The following is a description of a gene set: species: Homo sapiens Neighborhood of MT4 metallothionein IV in the MORF expression compendium Human Gene Set: MORF_MT4 Neighborhood of MT4, and this is the list of marker genes: FOXE1, MOK, AFF2, PVT1, NRTN (neurturin), CRYBA4, PAX8, CDK13 (cyclin dependent kinase 13), DTNA, MTX1, GLE1, KRT33A, PLIN3, LTK, ZNF592, BTD, DTX4 (NCBI Gene Id 23220), CTRL, ECE2, BRD1, NCKIPSD, RFC1, LAIR1, NEURL1, SFSWAP, CPSF4, LSM12, CSTF3, PEX6, B4GALT3, COLQ, SPEF1, SLC22A6, ATP6V1B1, IPCEF1, CNOT2, NR3C1, PCGF1, F7, PIK3CB, POU6F1, FUT6, PHF21A, ATP6V0A2, TMEM11, ZP2, KRT86, ZNF32, RANBP2, HTR4, CD8B, CLPX, CHD9, CNTN2, NRP2, FOXN3, ROCK1, HAUS5, UGT2B15, SUMO4, AAK1, MT4, NR2C1 (NCBI Gene Id 7181), CYP11A1, HNRNPL (heterogeneous nuclear ribonucleoprotein L), POLR2K, SMC5, SH2B1, TAF5L, ERCC2, SLC12A4, RWDD3, MYO9B, ECE1, RBBP8, FLT1, SEC31A, SLC22A24, JAG1, SIK3, MC5R, BAHD1, ADAMTSL2, TFDP2, LTBP4 (latent transforming growth factor beta binding protein 4), SLC4A3, IKZF1, CAMK2G, SLC24A1, MSX1, GRIP2, GTSE1, ARC, FRYL, IRF2, CLBA1, CMA1, TM4SF5, MSL3 (NCBI Gene Id 25867), GRIK5, TSPO2, JRK, PAXIP1, RASSF1, KANK3, EXTL3, STK17A, CRAT, DDX11, SLC13A2, MMP25, KCNJ4, CLP1, SLC6A11, KIFC3, ADAM15, TNKS, RPS6KB2, PNMT, PAX9, LEPROTL1, SLC2A1, KLHL18, PCBP3, KANK2, SLC18A1 (solute carrier family 18 member A1), DPT, OGG1, IRF2BP1, AQP5, LMO1, FANCG, PSMF1, ENTREP3, HTR7 (5-hydroxytryptamine receptor 7), BCL2 (NCBI Gene Id 596), PRELID3A, CRCP, GPATCH8, CRYAA, SLC25A11, AMFR, HOXD4, RNF139 (ring finger protein 139), ZKSCAN3, RERE, TBC1D22A, BPHL, NF1, RUNX1, ZBTB17, ARSL, ADD2, PIGR, STK19, POLR3D, SLC6A9, ZNF500, MPP2, SEZ6L, GPR35, CDK5R2, COX6A2, ESR1, HSPB2, KRR1, CBARP, ITIH4 (inter-alpha-trypsin inhibitor heavy chain 4), LRCH4, CACNB2, OPRL1, RAP1A, PIGB, DAPK2, ZNF710, LCOR, PML, TLN2, ZDHHC18, FRG1, JAK3, KIAA0586, LY9, NFRKB, PICK1, TNFRSF25, ATRX, PLEKHB1, FDXR, CRHR2, NUDT3, TTC22, WIPF2, CEP350, AGPS, TMEM94, HMGCS2, FOSL1 (FOS like 1, AP-1 transcription factor subunit), CYP2A6 (cytochrome P450 family 2 subfamily A member 6), PLK3, ST13, IL13, INPP5E, NEUROD2, MLN, NFYB, CHD3, IMPA1, HSD17B3, SSTR5, TTI1, SLC16A5, UTRN, WDR62, CCKAR, AANAT, MC2R, TBX5, IKBKE, LSM1, SLC6A7, ALDOC, SLC30A1, PRKCSH, PARVB, LBP, SLC30A3, SLC5A2, ANTXR1, EML3, ITPR2, ACKR2, FCHO1, BMP10, ESR2, DKK4, DOK1, DPYSL4, EEF1AKMT3, GALNT2, TUBGCP4, ZNF292, AQP7, NEK9, ENTREP1, SUN2, JMJD6